The following is a description of a gene set: Human Gene Set: HP_HYPOGLYCOSYLATION_OF_ALPHA_DYSTROGLYCAN A reduction in the degree of glycosylation of alpha-dystroglycan in muscle tissue. Hypoglycosylation of alpha-dystroglycan species: Homo sapiens, and this is the list of marker genes: LARGE1, FKTN, DAG1, POMGNT1, FKRP, POMT1, POMK, GOSR2, POMT2, CRPPA, GMPPB